Given this list of marker genes Rgs2, Fos, Dusp1, Mxd4, Smpdl3a (sphingomyelin phosphodiesterase, acid-like 3A), Ddx5, Cd28, Btg2, Skap1, Hmgb2, Abracl, Cd3d, Maf, Ctla4, Icos, Izumo1r, Cd3g, Atp11b, Rgs10, Stk17b, Jund, Trac, here is a description of the gene set: from publication Cui A, Huang T, Li S, Ma A, Pérez JL, Sander C, Keskin DB, Wu CJ, Fraenkel E, Hacohen N (PMID 38057668) Genes negatively differentially expressed in cell type: Treg upon treatment with cytokine: TL1A in mouse lymph nodes in vivo. Mouse Gene Set: CUI_TREG_TL1A_RESPONSE_DN Cytokines mediate cell-cell communication in the immune system and represent important therapeutic targets. A myriad of studies have highlighted their central role in immune function, yet we lack a global view of the cellular responses of each immune cell type to each cytokine. To address this gap, the authors created the Immune Dictionary, a compendium of single-cell transcriptomic profiles of more than 17 immune cell types in response to each of 86 cytokines (>1,400 cytokine-cell type combinations) in mouse lymph nodes in vivo. A cytokine-centric view of the dictionary revealed that most cytokines induce highly cell-type-specific responses. For example, the inflammatory cytokine interleukin-1β induces distinct gene programmes in almost every cell type. A cell-type-centric view of the dictionary identified more than 66 cytokine-driven cellular polarization states across immune cell types, including previously uncharacterized states such as an interleukin-18-induced polyfunctional natural killer cell state. studied in species Mus musculus